Given this list of marker genes TFDP3, TSC1, REST, SMARCB1, DEPTOR (DEP domain containing MTOR interacting protein), CRY2, AMPH, RBBP4, NFATC1, CCND1, GMNN, E2F4 (NCBI Gene Id 1874), SPRY2, DYRK1A, DLL1, CDK6, APP, SIRT1, CDKN1B, MLST8, GSK3B, RBL2, DNER, NOTCH1, TSC2, HIP1, CSNK1A1, LIN52, AKT1S1, MTOR, MAPT, TP53, HES5, EIF2B5, PSEN1, E2F5, FGF2, LIN54 (NCBI Gene Id 132660), TFDP2, RPTOR, LIN37, NCSTN, BACE1, CASP3, TFAP4, LIN9, NEUROG2, HES1, GLI1, LATS2, CASP9, TFDP1, DCAF7, H3-3A, DNM1, APH1A, FOXO1, CREB1, RBL1, CDK4, RAD54L2 (RAD54 like 2), PSENEN, here is a description of the gene set: species: Homo sapiens Human Gene Set: WP_DYRK1A_INVOLVEMENT_REGARDING_CELL_PROLIFERATION_IN_BRAIN_DEVELOPMENT DYRK1A involvement regarding cell proliferation in brain development